The following is a description of a gene set: studied in species Mus musculus Mouse Gene Set: GOCC_CHROMOSOME_TELOMERIC_REGION The end of a linear chromosome, required for the integrity and maintenance of the end. A chromosome telomere usually includes a region of telomerase-encoded repeats the length of which rarely exceeds 20 bp each and that permits the formation of a telomeric loop (T-loop). The telomeric repeat region is usually preceded by a sub-telomeric region that is gene-poor but rich in repetitive elements. Some telomeres only consist of the latter part (for eg. D. melanogaster telomeres)., and this is the list of marker genes: Wrnip1, Dna2, Hnrnpa2b1, Terb1, Rad51, Sun1, Pif1, Tnks2, Gatad2b, Pml, Spo11, Lrif1, Alyref2, Trp53bp1, Rad17, Ezh2, Alyreffm1, Thoc6, Blm, Hdac2, Spdya, Alyreffm11, Rad51d, Zbtb10, Dclre1b, Rbbp4, Thoc1, Nsmce1, Cbx1, Alyreffm8, Atf7, Nabp1, Rpa2, Zscan4f, Thoc2, Polr2b, Orc2, Nlrp2, Recql4, Stn1, Tox4, Dmc1, Alyreffm5, Majin, Nsmce3, Slx4, Upf1, Terf2, Hmbox1, Alyref, Eid3, Nabp2, Xrcc4, Chek1, H2bw2, Men1, H3f3b, Xrcc5, Ppp1cc, Smg6, Orc4, H2ax (H2A.X variant histone), Smc6, Alyreffm6, Hat1, Alyreffm10, Terf2ip, Chd4, Zscan4c, Zscan4d (NCBI Gene Id 545913), Atrx, Sun2, Ppp1ca, Cdk2, Acd, Rtel1, Fen1, Pot1a, Pold1, Wrap53, Wdr82, Pinx1, Rbbp7, Lrwd1, Tfip11, Wrn, Gar1, Zbtb48, Xrcc1, Tinf2, Ppp1r10, Rad51ap1, Ercc4, Mre11a, Terb2 (NCBI Gene Id 74401), Brca2 (NCBI Gene Id 12190), Rif1, Nsmce2, Thoc7, Alyreffm9, Smc5, Alyreffm3, Ppp1cb, Dhx36, Alyreffm4, Tert, Setx, Ctc1, Pot1b, Terf1, H3f3a, Nbn, Tnks, Mta2, Rnf8, Orc1, Atm, Thoc3, Chek2, Thoc5, Zfp827, Ppp1ccb, Alyreffm7, Smchd1, Cbx5, Sirt6, Thoc2l, Telo2, Ten1, Ezh1, Tep1, Rad50, Ercc1, Kdm1a, Kash5